The following is a description of a gene set: from publication Boquest AC, Shahdadfar A, Frønsdal K, Sigurjonsson O, Tunheim SH, Collas P, Brinchmann JE (PMID 15635089) Genes down-regulated in cultured stromal stem cells from adipose tissue, compared to the freshly isolated cells. Stromal stem cells proliferate in vitro and may be differentiated along several lineages. Freshly isolated, these cells have been too few or insufficiently pure to be thoroughly characterized. Here, we have isolated two populations of CD45-CD34+CD105+ cells from human adipose tissue which could be separated based on expression of CD31. Compared with CD31+ cells, CD31- cells overexpressed transcripts associated with cell cycle quiescence and stemness, and transcripts involved in the biology of cartilage, bone, fat, muscle, and neural tissues. In contrast, CD31+ cells overexpressed transcripts associated with endothelium and the major histocompatibility complex class II complex. Clones of CD31- cells could be expanded in vitro and differentiated into cells with characteristics of bone, fat, and neural-like tissue. On culture, transcripts associated with cell cycle quiescence, stemness, certain cytokines and organ specific genes were down-regulated, whereas transcripts associated with signal transduction, cell adhesion, and cytoskeletal +CD105+CD31- cells from human adipose tissue have stromal stem cell properties which may make them useful for tissue engineering. studied in species Homo sapiens Human Gene Set: BOQUEST_STEM_CELL_CULTURED_VS_FRESH_DN, and this is the list of marker genes: CPVL, ITIH5, APOE, IGF1, ADH1B, NAALAD2, CD14, CFD, TPPP3, C3 (NCBI Gene Id 12266), SPARCL1, OMD, FABP4, PTGER4, PPL, APOD, DPT, C7, TMEM176B, PDGFRL, SERPINA5, SOCS3, CXCL14, FOSB, RGCC (regulator of cell cycle), NTRK2, OGN, WNT11, CHL1, CCN5 (cellular communication network factor 5), MYOC